The following is a description of a gene set: species: Homo sapiens Small for gestational age Human Gene Set: HP_SMALL_FOR_GESTATIONAL_AGE Smaller than normal size according to sex and gestational age related norms, defined as a weight below the 10th percentile for the gestational age., and this is the list of marker genes: VPS33B, NSF, FANCC (NCBI Gene Id 2176), ABCC8, MYH3, B4GALT1, DYRK1A, FBXL4, DALRD3, EPCAM, FLCN, WDR73 (WD repeat domain 73), RPS15A, MMACHC, PET100, INS (NCBI Gene Id 3630), GATA6, RPS7, HYMAI, CNOT1, TBR1, SKIC2, STAMBP, PIK3C2A, SMARCAL1, CTBP1, PEX2, HUWE1, NR1H4, IGF2, COG7, HNF1A, TRAIP, FAM111A, TALDO1, HEATR3, ZNF668, MAGEL2, PLAG1, MAMLD1, TMEM70, ORC1, ESAM, CCDC8, NUP188, ZFP57, MTO1, CYB5R3, COL1A2, ASH1L, SIX2, CTCF, GMNN, FANCA, SYNE1 (spectrin repeat containing nuclear envelope protein 1), SNRPN, RBBP8, ALB, MBTPS1, RPS26, CTNNB1, GRB10, MEG3 (NCBI Gene Id 55384), POR, UBR1, NSUN2, GNPTAB, RPL9, RPS19, RPL31, SIN3A, KANSL1, SRP54, GATA1, PTCD3, PTS, PNPLA6, CRIPT, ACTB (actin beta), KCNJ11, ABCB11, ZNF699, ASCL1, RPS20, CAV1, COX20, RPL8, CLTCL1, LRPPRC, SKIC3, MCTP2 (NCBI Gene Id 55784), TSR2, DNAJC21, NCAPD3, LONP1, ALG8, ABCB4, CLCNKB, LMBRD1, KIF22, RPL15, TRMT1 (NCBI Gene Id 55621), DEF6, TSHR, RPS10, IARS1, DNA2, MPV17, MAPKAPK5, CDKN1C, THRB, STAG1, CEP57 (centrosomal protein 57), CENPE, NGLY1, YIPF5, RPL26, NUDT2 (NCBI Gene Id 318), RPL35, TAPT1, PAX2, TAF13, AR, NDN, ADA2, RPS29, RPS6KA3, EHMT1, UQCRFS1, RNU4ATAC, COQ7, FARSB, WBP4, VARS2, POLR3A (NCBI Gene Id 11128), NR4A2, PPFIBP1, ERCC2, SALL1, DTYMK, INSR, RPL5, NDUFB8, FBN1, CORIN, RPL27, SLC25A24, TIMM22, ERCC6 (NCBI Gene Id 282965), OBSL1, MSX1, PQBP1, SPR, RPL18, ATP8B1, SMAD4, PDHA1, GRIN2A, SLC16A2, H19, IGF1, ACADVL, CPLX1, GCK, CARS1, PIK3R1, BSND, HADHA, OCA2, TP63, SLC35C1, HSD11B2, THOC2, EIF2S3, ANAPC1, PALB2, KARS1, STOX1, ZNF335, DLK1 (NCBI Gene Id 8788), NPHS1, RPS27, DHX9, NECTIN1, NCAPH, FGFRL1 (NCBI Gene Id 54966), PUF60, SLC26A2, POC1A, TRMT10A, PLAGL1, SEC61A1, KCNJ1, NDP, NSMCE3, RPL35A, WDR4, SLC4A10, TONSL, FANCD2, COL1A1, SBDS, NKX3-2, FLT1, RET, CREB3L1, VPS13B, GTF2E2, SNIP1, CDAN1, YY1, IRF6, CLCNKA, FZD4, PTF1A, BLM, EMG1, AUTS2, FIG4, UQCRC2, NSD2, PRKAR1A, PRPS1 (phosphoribosyl pyrophosphate synthetase 1), DNM2, PRDX1, RPS17, BUB1B, OTUD5, ALG12, ERCC5, FANCE, RECQL4, SUCLA2, RPL11, POLR1A, SRCAP, RPS28, MUSK, SHROOM4, CRLS1, GK (NCBI Gene Id 2710), PBX1, CAMK2B, LETM1, NDUFB7, IGHMBP2, LARS2, CUL7, EP300, RPS24, LRP5, CREBBP, ITPR1, PAM16, TBL1XR1, GUF1 (NCBI Gene Id 60558), PPP1R15B, NCAPD2, MRPS16, GALK1, PHOX2B, CCNQ, NDUFA6, CNTN1, SLC12A1, LIG4, RTL1, CYB5A, PPP2R3C, HMGA2